Given this list of marker genes CCKBR, PIP5K1C, PIK3CB, PIP4K2C, PIK3C2G, PIP5KL1, PI4KA, PIK3R2, PIK3R6, PIK3R3, ATM, PIP4K2A, PIK3C2A, PIK3CG, PI4K2A, PIP5K1B, PIK3C2B, PIK3R5, PIPSL, PIK3CD, PIP4K2B, PIP5K1A, PIK3CA, PIKFYVE, PI4K2B, PIK3C3, PIK3R1, PI4KB, IPMK, here is a description of the gene set: Human Gene Set: GOMF_PHOSPHATIDYLINOSITOL_KINASE_ACTIVITY Catalysis of the reaction: ATP + a phosphatidylinositol = ADP + a phosphatidylinositol phosphate. species: Homo sapiens